Given this list of marker genes DAG1, PRC1, RTKN, UTRN, ALKBH4 (NCBI Gene Id 54784), MAEA, PDXP, BLOC1S6, ANLN, KIF20B, MYH9, here is a description of the gene set: studied in species Homo sapiens A cytoskeletal structure composed of filamentous protein that forms beneath the membrane of many cells or organelles, in the plane of cell or organelle division. Ring contraction is associated with centripetal growth of the membrane that divides the cytoplasm of the two daughter cells or organelles. Human Gene Set: GOCC_CONTRACTILE_RING